The following is a description of a gene set: from publication Lee Y, Awasthi A, Yosef N, Quintana FJ, Xiao S, Peters A, Wu C, Kleinewietfeld M, Kunder S, Hafler DA, Sobel RA, Regev A, Kuchroo VK (PMID 22961052) Genes down-regulated in comparison of untreated CD4 T cells versus those treated with TGFB3, IL6 and IL32A. TGF-beta3 produced by developing Th17 cells induces highly pathogenic T cells that are functionally and molecularly distinct from TGF-beta1-induced Th17 cells. The microarray data represent a distinct molecular signature for pathogenic versus non-pathogenic Th17 cells. studied in species Homo sapiens Human Gene Set: GSE39820_CTRL_VS_TGFBETA3_IL6_IL23A_CD4_TCELL_DN, and this is the list of marker genes: RHOQ, CRELD1, COMMD7, CYTH4, CCDC107, MEX3D, TGM1, FABP1, C3, RPN2, PARP16, NTF3, OCIAD2, MPST, TUBA3C, ARIH1, AHRR, ALPK2, FASTK (Fas activated serine/threonine kinase), OSM, USP5, PIP4P1, UBE2Q2, RARA, NOP9 (NCBI Gene Id 161424), DACH2, PARVG, FXR2, OGG1, ADAM9 (ADAM metallopeptidase domain 9), SMPD1, DEF6, CYP1B1, PEX11B, MAF, AREL1, PIWIL2, CPT1A, GFER, CCNI, HERPUD1, ARMCX2, DCTN4, ARL2, CCNO, ACVRL1, PEX13, CRTAP, TRIP10, FNDC3A, MTSS1, ASPSCR1, VAMP4, ANKRD54, HADH, BRF2, NR1H2, YIF1B, EEFSEC, ALDOA, YARS1, CXXC1, BEND4, CAVIN2, NPLOC4, PPM1J, CHAF1B, MLX, ROS1, ITGA7, ATF5, EDEM2, PTTG1IP, GADD45G, PLAC8, UCP2, NFE2L2, NR1D1, RHOH, PRMT5 (protein arginine methyltransferase 5), AMDHD2, RPS18, FANCE, PKM, PFN2, PAPSS1, CAMK4, SCPEP1, AHCY, GPR15, IBA57, PSTPIP1, GNA11, LYSMD3, CENPB, NINJ1, PITX1, KYAT1, KDELR1, STAT3, ZBTB21, PPP1R14C, PTBP1, CERS4, CD28, YJU2, FIZ1, SNAPC2, TPGS1 (tubulin polyglutamylase complex subunit 1), C19orf12, BANF1 (barrier to autointegration nuclear assembly factor 1), CCND3, DCAF8, SOCS3, SMIM14, COX18, HS3ST6, COPA, CRLF2, SDCBP2, TMEM248, MED19, TXNDC5, MALT1, SYPL1, XKRX, MRI1, CDIPT, ZFP36L2, MACO1, RNF220, VARS1, SRA1, GALT, ARHGDIB, NXPE3, LCE1D, IYD, GLA, WIPI2, DNAJA4, MAEA, PAQR8, MEN1, GAPDHS, SUCLG1, MAP2K6, NET1, STN1, CUTA, ARHGEF10, TAF6L, ORAI3 (ORAI calcium release-activated calcium modulator 3), RGS19, GPR108, UBQLN1 (ubiquilin 1), EMP1, UTP14A, RNF149, PCBP4, CNPPD1, WDR1, ITPRID2, TRPM4, C6orf120, REEP4, HNRNPL, UTY, GCNT1, ATP6V0E1, MIIP, USP22, MCRIP1, APEX2, TRPC4AP, BTBD8, HAUS8, SUSD3, GPR180, IMPA2 (NCBI Gene Id 3613), MUL1, RUVBL2, SLC4A5, ARFIP2, BIN1, RHOBTB1, RNF125, PC, RMC1, PHETA1, CENPN, ESPN, ALDH1B1, LRRC59, ARHGEF39, PMP22, TXNIP, OCEL1, USF1